Given this list of marker genes Tirap, Hmgb1, Mfhas1, F2rl1 (NCBI Gene Id 14063), Cyba, Tlr1, Pja2, here is a description of the gene set: Mouse Gene Set: GOBP_POSITIVE_REGULATION_OF_TOLL_LIKE_RECEPTOR_2_SIGNALING_PATHWAY species: Mus musculus Any process that activates or increases the frequency, rate, or extent of toll-like receptor 2 signaling pathway.